Given this list of marker genes Napsa, Gnb4, Uqcc2, Ftsj3, Fh1, Sem1, Mrpl55 (NCBI Gene Id 67212), Snn, U2af1, Cox17, Serpina3g (serine (or cysteine) peptidase inhibitor, clade A, member 3G), Tarm1, Orai1, Clec4n, Rara, Tpm3, Rap1a, Lcp1, Srsf9, Cltc (NCBI Gene Id 97762), Arhgap31, Pacsin2, AA467197, Cox8a, Pfkp, Prkcd, Plek, Ier3, Slc30a4, Fnbp1l, Ms4a6d, Actr3, Slc2a1, Wdfy4, Eml4, Bcl2a1b, Necap2, S100a4, Pdia3, Pfn1, Xbp1, Set, Dok2, Scimp, Naaa, Vasp, Idi1, Ffar2, Psme2, Efhd2, Cst3, Snrpd3, Kmo, Hycc2, Hnrnpa3, Dusp7, Uck2, Snx3 (sorting nexin 3), Irf4, Trio, Cish, Prps1, Sdc4, Psma3, Ccl17, Jak2, Ran, Coro2a (coronin, actin binding protein 2A), Tuba4a, Snrpe, Rab14, Hnrnpab, Vim, Ctsz, Bcl2a1d, Ptpn1, Syngr2, Tuba1b, Vrk1, Snrpd1, Slfn2 (NCBI Gene Id 20556), Kynu, Cdkn1a, Socs1, Bcl2a1a, Arl8b, Pim1, Cd209e, Fabp5, S100a6, Rras2, Lamtor2 (NCBI Gene Id 83409), Il4i1, Pnp, Rap2a, Hspa5, Cyp4f16, Ncl, Hnrnpk, Ciita, Tns1, Cflar, Mrpl36, Atox1, here is a description of the gene set: Genes positively differentially expressed in cell type: cDC2 (conventional dendritic cell type 2) upon treatment with cytokine: TL1A in mouse lymph nodes in vivo. Cytokines mediate cell-cell communication in the immune system and represent important therapeutic targets. A myriad of studies have highlighted their central role in immune function, yet we lack a global view of the cellular responses of each immune cell type to each cytokine. To address this gap, the authors created the Immune Dictionary, a compendium of single-cell transcriptomic profiles of more than 17 immune cell types in response to each of 86 cytokines (>1,400 cytokine-cell type combinations) in mouse lymph nodes in vivo. A cytokine-centric view of the dictionary revealed that most cytokines induce highly cell-type-specific responses. For example, the inflammatory cytokine interleukin-1β induces distinct gene programmes in almost every cell type. A cell-type-centric view of the dictionary identified more than 66 cytokine-driven cellular polarization states across immune cell types, including previously uncharacterized states such as an interleukin-18-induced polyfunctional natural killer cell state. from publication Cui A, Huang T, Li S, Ma A, Pérez JL, Sander C, Keskin DB, Wu CJ, Fraenkel E, Hacohen N (PMID 38057668) studied in species Mus musculus Mouse Gene Set: CUI_CDC2_TL1A_RESPONSE_UP